The following is a description of a gene set: The aggregation, arrangement and bonding together of the mature ribosome and of its subunits. Human Gene Set: GOBP_RIBOSOME_ASSEMBLY studied in species Homo sapiens, and this is the list of marker genes: DHX30, RPS5, MTG2, RRP7BP, MTERF4, BOP1 (NCBI Gene Id 727967), METTL17, C1QBP (NCBI Gene Id 708), ABT1, RPS28, NOA1 (nitric oxide associated 1), RPS15, FAU, MTERF3, PWP2, RPL5, XRCC5, DHX37, NOP53, MIURF, RPS6, NGRN, MPV17L2, NPM1, NOP2, EIF5, RPSA2, VCX, MDN1, NIP7 (NCBI Gene Id 51388), RPSA, DHX29, RPS27L, BRIX1, RPL24, RPL38, EIF5B, MCAT, RPL11, RPS27, DDX3X, MRPS7, SBDS, ERAL1, MRTO4, MTG1, RPF2, EIF6, PRKDC, DDX28, MRM2, RPS14, EFL1, RRP7A, RCC1L, MRPS2, MPV17L (MPV17 mitochondrial inner membrane protein like), RRS1, RPL10L, EIF2A, FASTKD2, EIF1AX, RPS19